The following is a description of a gene set: Marker genes curated from the annotated cluster as represented in the Descartes Human Gene Expression During Development database. The gene expression program underlying the specification of human cell types is of fundamental interest. The study authors generated human cell atlases of gene expression and chromatin accessibility in fetal tissues. For gene expression, the study authors applied three-level combinatorial indexing to >110 samples representing 15 organs, ultimately profiling ~4 million single cells. The study authors leveraged the literature and other atlases to identify and annotate hundreds of cell types and subtypes, both within and across tissues. Our analyses focused on organ-specific specializations of broadly distributed cell types (such as blood, endothelial, and epithelial), sites of fetal erythropoiesis (which notably included the adrenal gland), and integration with mouse developmental atlases (such as conserved specification of blood cells). These data represent a rich resource for the exploration of in vivo human gene expression in diverse tissues and cell types. Human Gene Set: DESCARTES_FETAL_LIVER_HEPATOBLASTS studied in species Homo sapiens from publication Cao J, O'Day DR, Pliner HA, Kingsley PD, Deng M, Daza RM, Zager MA, Aldinger KA, Blecher-Gonen R, Zhang F, Spielmann M, Palis J, Doherty D, Steemers FJ, Glass IA, Trapnell C, Shendure J (PMID 33184181), and this is the list of marker genes: SAA4, KNG1, OGFR-AS1 (OGFR antisense RNA 1), SALL1, A1BG, ERRFI1, PORCN-DT, AFP, SLC38A11, TAFA4, LINC01370, SULT1E1 (NCBI Gene Id 6783), MGST1, SMLR1, MYORG, FAM9A, MIR122HG, A1CF (APOBEC1 complementation factor), LINC02672, KRT222, SGK2, BCAR3-AS1, EPB41L4B, C1orf115, RNU6-117P, SLC6A11, HJV, PECR, KLB, C8B (NCBI Gene Id 732), C1orf210, ACOT12, TRPC5, FOLH1B (folate hydrolase 1B (pseudogene)), GC (GC vitamin D binding protein), IL17RB, HAL, SLCO1A2, GLS2, CASC17, AGT, HNF4G, PPP2R2B, PPARGC1A, TAT, PEBP1, ANKS4B, ANXA13, LINC02754, APOA2, NUGGC (NCBI Gene Id 389643), EFHD1, GLDC, LINC02532, FGFR3, ACSL3P1, FXYD2 (FXYD domain containing ion transport regulator 2), SLC2A2, FABP1, LINC00574, AGXT, MST1P2, APOA4, APOA5, XDH, HMGCS1, ACADSB, TDO2, MSMO1, ASGR2, LINC01900, BHMT, DDC, UGT2B4, G6PC1, CPS1, LDHD, AGMAT, C8A, SLC22A9, TF, LINC02607, GGCX, KIF12, UGT2B10, SLC22A3, GPT, WDR72, SGIP1, COL2A1, ACSM2B, SLC17A1, GPC5-IT1, CYP4F2, KCNU1, SLC39A14, FOXP2, DPYS, CNGA1, ANG, FOXA2, LAD1, MT1F, BDH1, UGT2B15, RPS26P57, SLC13A5, HPR, PLGLA, VTN, GAS2, ART5, APOA1, RNA5SP163, DIO1, CAMK2N1, ALDH1A1, CCDC198, STEAP2, TTC36, HGFAC, GLYAT, AKR1D1, CPN2 (carboxypeptidase N subunit 2), MAOB, PRSS46P, ENSG00000228697, ASS1, SLC22A7, PALMD, AZGP1, FGB, SMAD3-DT, POU6F2-AS1, GLTPD2, LINC01717, TM7SF2, ACSM2A, ENSG00000264422, ALDOB, SLC16A12, PLA1A, SPTLC3, SERPINC1, ADORA2A-AS1, RPL23AP6, IGSF1, P2RX3, SERPIND1, KIF6, HAMP, PLA2G12B, MAB21L4, SERPINA11, NGEF, CYP3A7, PDZK1, LINC02609, ADM2, LINC02027, ALDH1L1-AS2, MROH9, FADS6, GLYATL1, CYP4F3, F9, AKR1C3, GSTA2 (NCBI Gene Id 2939), SLC47A1 (solute carrier family 47 member 1), FYTTD1P1, DGAT2, PROX1, GJB1, ANGPTL3, SLC17A3, LINC02499, SERPINA6, UGT2A3, PRAP1, CDO1, CYP4A11, PLCXD2, REEP6, SLC22A25, PROX1-AS1, SLC38A4, PEG10, CTXND1, C2orf72, MLXIPL, APOH, ALDH1L1-AS1, FAM151A, PNPLA3, ARSL, TMEM54, SERPINA5, BAAT, MSI1, TMEM199, LINC01816, AMDHD1, DBI, HGD, AMN, TCEA3, SERPINA7 (serpin family A member 7), MUSTN1, C4BPA, PALM3, NPC1L1, PSAT1, ABCG5, SLC39A5, GTF2IP7, HNF4A, TMEM139, LINC02331, TM4SF4, RAB26, UGT2B7, B3GAT1-DT, MST1L, CFHR1 (NCBI Gene Id 82407), ONECUT1, AHSG, SHH, PERP, CFHR3, EHHADH, ALDH4A1, ITIH3, UROC1, MBL2, HAO1, SLC34A1, PIK3C2G, NR1I3, ZFHX4-AS1, AMBP, HABP2, FFAR4, LINC03064, F2, ASAH2B, IGSF23, PLPPR1 (phospholipid phosphatase related 1), MLIP, SERPINA1, FOXN4, LINC00482, XPNPEP2, NR0B2, CP, DUSP9, SLC22A10, LRRC9, PDCD1, FGFR4, TJP3, RNASE4, APOC2, MT1E, ALDOC, MAOA, ENSG00000230894, LPA, F11, FST, ALB, ASGR1, RHBG, THRB, SLC16A11, MFFP1, SPP2, AADACP1, F12, APOC4, ARG1, LINC00939, ABCG8, C6, PRODH2, HNF1A-AS1, CTNND2, GLT1D1, THRB-IT1, LINC00261, SLC17A2, VSNL1, HOGA1, ABCC6, AK4 (adenylate kinase 4), ENPP7, GBA3, MYH14, HNF1A, LINC02919, HPN-AS1, TTPA, SYNE4, SLC19A3, UGT2B27P, CACNA1D, CAMSAP3, HPN, SHANK2, SMOC1, CCT8P1, LINC01942, SERPINA4, CDHR3, PPP1R1C, ALDH1L1, MOGAT1, MOGAT3, MOGAT2, SLC17A4, SLC6A1, LINC02934, KLKB1, ATF5, TOX3, ITIH2, CA5A, ONECUT2, SULT1C2, ELOVL2 (ELOVL fatty acid elongase 2), C5, SLCO1B3, CFB, MRPL23-AS1, ENSG00000201368, FETUB, GPC3, PBLD, APOM, AGMO, ALDH8A1, AADAC, SOAT2, CHDH, TMPRSS6, RNU4ATAC3P, F13B, TTR, PHYHIPL, CDHR5, TAT-AS1, SC5D, CYP2J2, MARVELD3, RN7SL583P (NCBI Gene Id 106481082), SLC2A9, DHCR7, ADH6, LIPC, STEAP2-AS1 (STEAP2 antisense RNA 1), SDC1, PAH, KLF15, FGG, APOE, FMO3, SLC6A12, MTUS1-DT, MGC32805, CFHR4, CPB2, ENPP1, CPN1, FOXA1, SERPINA3, ENSG00000233569 (novel transcript), HISLA, RBP4, RPS3AP54, CHAD, HKDC1, APOF, GLUD1, PLG, FN1, HPX, MT1X, ETV4, ACMSD, FBP1, LINC01428, APOC1 (apolipoprotein C1), RGN (regucalcin), PTP4A1, F10, ANPEP, ADH1A, TRIM55, FGA, BBOX1, PKHD1, SERPINF1, CASC19 (NCBI Gene Id 103164619), CYP3A43, H19, FMO5, LIPG, GPAM, GPC5, QRSL1P1, ERBB3, LINC00616, RN7SL674P, SERPINF2, GREB1, SLC47A1P2, RIDA, TENM1, HRGP2, SLC25A47, AFM (NCBI Gene Id 173), SOWAHA, SLC26A1, SLCO1B1, ABCC2, MTTP, RN7SL359P, LINC00470, LINC01843, MT1G, IYD (NCBI Gene Id 389434), RNU1-30P, LINC02015, CYP19A1, PCK1, ITIH1, MT2A, APOC3 (apolipoprotein C3), SLC15A1, RNF128, CAPN12, FTCD, CLDN14, HRG, SLC25A18, CRYZ, KRT6C, BHMT2, EPO, AKR1C2, PROZ, LINC02365, MAT1A, PLEKHG6, ADH4, ACSL4, APOB, DCDC2, SNORC, CREB3L3, CYP3A5, VIL1, IGFBP1, ERVK9-11, SLC5A11, MT1H, SLC22A24, SCD, TMEM82, FGL1, SLC29A4, C4BPB, GYS2, HMGCS2, ACE2, HSD17B2, FAM3D-AS1, MPC1-DT, PROC, TTC6, PCSK9, NPSR1-AS1, SLC38A3, ACOX2, EIF2S2P2, LRRC31, ASPDH, PHYH, SNAP25-AS1, SUGCT, SERPINA10, SLC7A2, GJB2, F7, HLMR1, SEMA4G, AGXT2, LBP, AOC4P, LINC00907, LINC02851, ABCC6P1, ALDH6A1, LINC00870, GCGR, MT1M, DQX1, MEP1A